The following is a description of a gene set: Human Gene Set: PIAS4_TARGET_GENES Genes containing one or more binding sites for (PIAS4) in their promoter regions (TSS -1000,+100 bp) as identified by GTRD version 20.06 ChIP-seq harmonization. species: Homo sapiens from publication Yevshin I, Sharipov R, Kolmykov S, Kondrakhin Y, Kolpakov F (PMID 30445619), and this is the list of marker genes: H1-2, MIR4757, STOML1, H2AC12 (NCBI Gene Id 85235), CA1, VPS37B, RALGAPA1, CCDC106, RBKS, PDE4A, ZNF580, H3C10, GARIN5A, MYOSLID-AS1, PRMT5-AS1, H2BC3, MSRB2, H4C2, DOK1, LINC00114, DNAJB2, JOSD2, ADAMTS9-AS2, RPL38, HES4, LOXL3, FBXO34, DXO, SPAG4, TSPAN31, KICS2, UQCC4, AHDC1 (AT-hook DNA binding motif containing 1), TMEM259, CDC14B, METTL25B, TP53BP1, H2BC12, H3C12, ZBTB21, H4C5, MIR3143, H4C8, STK19, FBXO34-AS1, ACSM3, STAP2, PML, SERPINA7, CSNK1G2, COL6A1, EMD, ISG15, HECA, TMEM241, CREB1, H2BC5, CAPN1, FAM53C, BRAF, VCAN, PPFIA3, ISG20L2, H2AC8, RHBDD1, ZNF581, EMC10, CRYBB2, IFT46, NUDT18, RFX1, NSUN4, LINC00930, CSNK2A1, LINC02453, RNU6-921P, H2AC5P